The following is a description of a gene set: Human Gene Set: KEGG_MEDICUS_REFERENCE_INACTIVATION_OF_CONDENSIN_I species: Homo sapiens Inactivation of condensin I. Pathway ID: N01501. Pathway type: Reference. Pathway class: nt06512 Chromosome cohesion and segregation. Pathway Definition from KEGG: CK2 -| SMC4,NCAPD2,NCAPG,NCAPH, and this is the list of marker genes: SMC4, CSNK2A2, NCAPG, NCAPD2, NCAPH, CSNK2A1